The following is a description of a gene set: Mouse Gene Set: GOBP_REGULATION_OF_CELL_SIZE species: Mus musculus Any process that modulates the size of a cell., and this is the list of marker genes: Slc12a1, Sin3a, Limk1, Ilk, Megf8, Anxa7, Dbnl, Fshr, Rapgef3, Vav2, Xk, Vav1, Rtn4r, Srf, Aqp4, Mag, Clcn3 (chloride channel, voltage-sensitive 3), Atp7a, Wdtc1, Gdi1, Smurf1, Bcl11a, Plek, Mfn2, Rb1cc1, Sema3g (NCBI Gene Id 218877), Fn1, Dscam, Pou4f2, Hsp90aa1, Vav3, Slc12a2, Add1 (adducin 1), Wnk1, Akt3, Aqp11, Draxin, Col6a1, Nrp1, Slc26a5, C1qtnf9, Creb1, Wdr36, Eif4g2, Wnt3a, Hsp90ab1, Ifrd1, Rdx, Rac1, Sema3f, Ptprs, D130043K22Rik, Il7r, Ttl, Cln8, Omg, Slc12a7, Mtor, Trim46, Gprc5b, Tsc1, P2rx7, Wnt5a, Oxsr1, Ano6, Hdac6 (NCBI Gene Id 20374), Map1b, Cttn (NCBI Gene Id 68623), Efna5, Fxn, Kdm1a, Sema6d, Epha7, Slc12a3 (NCBI Gene Id 20497), Fgf13, Sema5a, Sct, Ucn, Wnk3, Lpar3, Slc12a8, Map3k7, Akt1, Ahr, Myo5b, Cln3, Plxna4, Lrp1, Cav3, Ntrk3, Ttc3, Sema6c, L1cam, Eif2b2, Ngf, Actr3, Rnf6, Kdm6a, Msn, Vegfa, Arhgap4, Slc6a12, Nherf1, Slc12a6, Ret, Slit2, Cdh1, Lrrc8e, Prkg2, Rgma, Akt1s1, Adcy10, Dcx, Mtpn, Ep300, Mgll, Cdkl5, Ndel1, Cdk4, Arhgap32, Slc12a9, Twf2, Macf1, Disc1, Lars1, Slit1, Golga4, Rptor, Ulk2, Barhl2 (NCBI Gene Id 54444), Ccdc51, Pum2, Ulk1, Abcb8, Prkd1, Mir205 (microRNA 205), Mt3, Rhoa, Rufy3, Atp2b2, Slc12a4, Ryk, Stk39, Spart (spartin), Dip2b, Aqp1 (aquaporin 1), Deptor, Lrrc8a, Cdh4, Bmpr2, Edn1, Pten, Tsc2, Sema7a, Map2, Nkx6-1, Prr16, Lamtor4, Cxcl12, Clasp2, Aqp2, Wnt3 (NCBI Gene Id 22415), Tnr (NCBI Gene Id 21960), Ogt, Bdnf, Islr2, Trp73, Cdk5, Plxna3, Rab21, Kel, Ccr5 (NCBI Gene Id 235693), Rnd2, Npm1, Gsk3b, Map3k13, Olfm1, Anapc2, Fstl4, Slc12a5, Rtn4, Dnm2, Lamtor5, Shank3, Cdkl3, Mapt, Sema4d, Sema4f, Pak1, Dbn1, Shtn1, Tnfrsf12a, Vpreb1b, Ntn1, Sema3a, Arhgap5, Sctr, Pafah1b1, Arhgap35, Abl1, Trpc5, Vpreb1a, Gnb3, Crabp2, E2f4, Adnp, Iqgap3, Kcnn4, Ist1 (NCBI Gene Id 71955), Rpl4, Zfyve27, Cfl1, Trpv2, Clns1a, Apoe (NCBI Gene Id 11816), Cyfip1, Kcnma1